Given this list of marker genes ZNF654 (zinc finger protein 654), MCM7, TUBA4A, SYNCRIP, MMS22L, SIK2, SEC61A1, MIS12, DLGAP4, MCM3, PDS5A, PRRT2, LUC7L2, CNTFR, WEE1, RREB1, GDI1, CENPH, PTGR3, LIG1, DCLRE1A, ZSWIM9, USP32 (ubiquitin specific peptidase 32), RMI2, PRIM1, GNAQ, PRPF38A, EZH2, AP4M1, CDCA7, SRSF1, CCNJL, TUBA3E, RIN2, R3HDM1, DMRTB1, SRSF7, MEPCE, BCAS3, KCND2, TOPBP1, BRMS1L, DDB2, CADM1, SPRED1, RANBP1, FAM50A, TIMM23, ZCWPW1, UHRF1, SEMA5A, DAXX, BTBD10, FLRT1, MCM6, ZBTB8OS, ORC1, TRMT2A, BOLL, PIM1, PRMT3, RBBP4, YARS1, FYB1, RFC4, EPB41, MYC, SH3BP1, RCOR2 (REST corepressor 2), CNBP, B3GNT9, ZMYM4, POLD1, SH3KBP1, ZHX2, TUBA4B, NHLRC2, here is a description of the gene set: studied in species Homo sapiens Comprehensive identification of all functional elements encoded in the human genome is a fundamental need in biomedical research. Here, we present a comparative analysis of the human, mouse, rat and dog genomes to create a systematic catalogue of common regulatory motifs in promoters and 3' untranslated regions (3' UTRs). The promoter analysis yields 174 candidate motifs, including most previously known transcription-factor binding sites and 105 new motifs. The 3'-UTR analysis yields 106 motifs likely to be involved in post-transcriptional regulation. Nearly one-half are associated with microRNAs (miRNAs), leading to the discovery of many new miRNA genes and their likely target genes. Our results suggest that previous estimates of the number of human miRNA genes were low, and that miRNAs regulate at least 20% of human genes. The overall results provide a systematic view of gene regulation in the human, which will be refined as additional mammalian genomes become available. Human Gene Set: KTGGYRSGAA_UNKNOWN from publication Xie X, Lu J, Kulbokas EJ, Golub TR, Mootha V, Lindblad-Toh K, Lander ES, Kellis M (PMID 15735639) Genes having at least one occurrence of the highly conserved motif M112 KTGGYRSGAA in the regions spanning 4 kb centered on their transcription starting sites. The motif does not match any known transcription factor binding site.